Given this list of marker genes ZBTB44, SH3D19, BMI1, LRRC4B, PRPF40A, DIAPH3, DNAJB14, MDFIC, HLTF, SRSF3, SLAIN1, NOTCH2, CYBRD1, TCF12, RNF149, ACBD5, MIER3, RICTOR, MMD, ACTN4, GCNT1, ASB3, ZNF652, DEFA6, MBNL2, CISD2, PTPRG, METTL8, EIF2AK2, FRMD5, HMBOX1, GTF3C3, ARK2N, CCDC117, PAQR9, TRAM1, IGF2BP3, GABPA, SMAD9, ARL6IP6, MYCN, TFDP3, PRKAA2, AFDN, IGSF3, WDR26, NAA30 (NCBI Gene Id 122830), GRIP1, ZNF326, CNTN1, GATM, TMED7, BEND7, PPHLN1, CLDN12, MAST4, GPC6, PROK2, FNIP2, UEVLD, PLEKHH2, GPR85, PRKG1, ZBTB20, PSMC2, HIPK1 (NCBI Gene Id 23323), SUMF1, PHYHIPL, CERS6, RIC1, HOXD13, ZNG1F, LIN7A, SYNM, FZD7, ZFAND5 (zinc finger AN1-type containing 5), PITX2, LVRN, NDC1, POU2F1, DNAJB4, ZDHHC15, CARF, CCNB1, LCTL, OGFRL1, PDE4D, A1CF, NRG4, CCDC47, ZBTB41, ZBTB10, SREK1, FGD4, NUP54, BTF3L4, TRIM9 (tripartite motif containing 9), SLC4A7, DAAM1 (dishevelled associated activator of morphogenesis 1), LSAMP, ZEB2, FMNL2, SERINC3, PPP1R2, ARID2, SCN8A, CHN1, MFN1, CEP350 (centrosomal protein 350), DIP2B, COL11A1, MAST3, ACADL, S1PR1, ATXN7L1, PPARG, U2SURP, TXLNG, ADAM30, IGF1, COMMD3-BMI1, ODAPH, RHPN2, RAB27B, FBXL3, PCDH11X, FOXG1, PRRC1, GLIPR1, SAMD8, CFL2, RHOQ, TNFRSF21, ZNF148, GULP1, PRP4K, C6orf120, GSE1, ZNG1E, CHST9, CBX3, MIER1, BBX, SCN3A, CTNNA3, LARP4, RGPD5, ACBD3, SAMTOR, UBE2A, KPNA4, MARCHF6, C5orf24, STEAP2, MIDEAS, DPY19L3, DDIT4, METTL6, DHRS1, SCN1A, SFT2D1, GOLGA6L2, TPM3, RASSF8, MAP4K4, SKIDA1, PRKAG2, TTC19, ONECUT2, NCKAP1, BBS10, ADAMTS1, EPB41L5, MBIP, BRWD3, TMEM65, FZD3 (NCBI Gene Id 7976), MINDY2, MBNL3, SNAP91, RO60, SFMBT1, RORA, APPBP2 (amyloid beta precursor protein binding protein 2), NFKB1, ZNF492, SECISBP2L, ACAT2, PAX5, ABI3BP, MAP9, MEIS2, EEA1, RALA, SESTD1, FEM1C, KIF20B, PGRMC2, PTBP3, UGT8, KCNJ3, EXOC5, LCOR, RBBP8 (RB binding protein 8, endonuclease), SNX16, ITGB6, GPD2, SENP1, NUMB, MIGA1, GPALPP1, TRPC5, SMG1, ZNG1A, SSR3, GNAQ, MECP2, ADGRB3, LRRTM3, SPATA6L, REV3L, NAV2, PTPRR, SERINC5, NDFIP2, CFDP1, DYNC1I2, PAPOLG, AIDA, NR2C1, NRXN1, SPOCK3, FAM133A, DYNC1LI2, FLRT3, SYTL5, CFAP44, CLCN4 (NCBI Gene Id 4412), SCML2, ANKRD26, DUSP7 (NCBI Gene Id 1849), CSNK1D (NCBI Gene Id 1453), MAML1, GSTCD, TMTC3, ZNF680, UTP3, ARL13B, B3GALT5, HECA, SF3A1, UNC80, GABRA4, MCF2L2, ELL2, FAM199X, URI1, RESF1, BOD1L1 (NCBI Gene Id 57219), CCDC179, ANAPC1, SRSF6, KLRD1, RFC3, LPP, DCDC2, MAGT1, PPP1R27, SDC2, SMAD5, GCC2, LACTB (NCBI Gene Id 84943), SOX5, TBCK, RNF217, WDR7, GABPB1, FYB2, TRA2B, MZT1, CAMSAP2, RC3H1, CRACD, HDAC9, CCSER1, KRT28, SLC24A3, SEC24A, KATNBL1, ATXN2, GUCY1A2, CAPN2, ZBTB25, GUCY1B1, CA8, CACNA2D3, LRP1B, RGS7BP, UBA6, ERC2, TMTC1, PRPF39, CD163, KLF7, MTA1, ZBTB11, XPNPEP1, C21orf91, SLU7, SETD2, CLVS2, ARRDC4, STYX, PRKAA1, TTC13, DENND1B, PDE1C, ALG11, SLCO5A1, KL, ZCCHC8, ANKRD22, TLCD4, PLEKHG1, CBFB, KIAA1586, TIFAB, JARID2, ZNF608, RGPD6, OAZ1, BNIP3, MTMR6, SLC30A5, LMCD1, SPDYE1, FNDC3B, WAPL, AHSA2P, HOMER1, DOLPP1, UGDH, SDF4, C9orf40, STXBP5 (syntaxin binding protein 5), PIWIL3, CCP110, TOLLIP, PDCD5, TP53INP1, CCDC50 (coiled-coil domain containing 50), RRAGD, FAM221A, ZNF792, MED6, BRWD1, PGAM1, CCNY, FGFR1OP2, ZNF486, TRUB1, RPS6KA5, CD99, AP1AR, KLF8 (KLF transcription factor 8), PPP1R9A, BTG3, ADAM22, RGPD8, NAT1, GASK1A, RAP2A, NFAT5, WDR47, ZNG1C, IKBIP, RETREG1, ZNF747, ANKRD46, THSD7A, ZNF503, MFSD8, HTR2C, PRELID2, PPP5C, SANBR, NEDD4L, C3orf38, FSBP, CAMLG, MGARP, ARMCX3, RMND5A, GAPVD1, TBCA, NUP50, LACTB2, TMEM200A, EVI2A, SPAG9, MMUT, ZRANB2, GRID2, RFX7, CSGALNACT2, MTF1, AQP3, SRP9, FGL2, LANCL1 (LanC like glutathione S-transferase 1), CMPK2, PPEF2, PREX2, ABCA5, BCL2L2, RAB8B, NTF3, CCNG2, NEGR1, LATS1 (large tumor suppressor kinase 1), CACUL1, ZDHHC21, ZNF454, MEX3D, RAP1A, HOOK3, TRPC1, CHRNA7, AGTR1, RGPD4, ADH5, FAM135A, EPHA3, PDZRN4, MTFR1, SIX4, GRM5, GRM7, YIPF5, SDE2, MMP16, ARFRP1, DTWD2, CDK6, TRIM2 (NCBI Gene Id 23321), PROSER1, FZD5, FIGN, NOS2, LMX1A, LRRC7 (leucine rich repeat containing 7), GPR155, CRIPT, ANKRD10, TMEM135, TMEFF2, TFAM, IKZF2, ITGAV, SCAMP1, AFTPH, C11orf87 (NCBI Gene Id 399947), SACS, CIAO2A, TMEM255A, ZNF559, SNX30 (sorting nexin family member 30), DUS4L, HNRNPDL, ME1, ZC3HAV1L, ZDHHC2, SEC22C, NUP160, CEP120, PTGFRN, TMEM167B, AK3, ACVR2B, BTG2, NOTUM, SCARF1, ANGEL2, EDIL3, GPATCH11, KLF10, GOPC, ETF1, RIMOC1, POLR2H, PCDH11Y, ATP11A, ADAMDEC1, RNF138, PCLO, ZNG1B, here is a description of the gene set: Human Gene Set: MIR548AK_MIR548AM_5P_MIR548C_5P_MIR548H_5P_MIR548O_5P_MIR548AU_5P Genes predicted to be targets of miRBase v22 microRNA hsa-miR-548ak, hsa-miR-548am-5p, hsa-miR-548c-5p, hsa-miR-548h-5p, hsa-miR-548o-5p, hsa-miR-548au-5p in miRDB v6.0 with MirTarget v4 prediction scores > 80 (high confidence targets). from publication Chen Y, Wang X (PMID 31504780) studied in species Homo sapiens